Given this list of marker genes DNAJA1, NTF3, IGFBP3, OR51E1, AGT (angiotensinogen), ATXN7, MYO5A, USP26, PAFAH1B2, SBSN, EHD3, FAM117B, SFMBT2, ZC3H12D, UBR1, CA12, FIBIN, CAPN7, TUBB1, RC3H1, ADAR, ARHGEF9, FBXO33, CD247, LRRTM2, NFKBIZ, KCNA5, CCN4, PPP1R42, TEX29, SFR1, KBTBD11, GLS, TSPAN5, HTRA3, IGIP, CST5, SOX3, HES7, CD69, BCAN, LIN37, STAT1, CRIP1, CACNB1, AKT3, FBXL5, MCL1, OR51B6 (olfactory receptor family 51 subfamily B member 6), RGS8, POM121L12, CHD6, OSCAR, DOCK3, COL8A1, CAST, RESF1, SLC1A4, GCOM1, TREML2 (NCBI Gene Id 79865), IAPP, SC5D (sterol-C5-desaturase), PIK3R6, RAI14, LATS2, MALT1, TNFSF9, MTURN, PLS1, ALKBH5, TMPRSS13, RBPJ, DTX3L, SOS1, CEP85, ATXN1, SIAE, ART3, TMCC3, VCPIP1, TSPAN13, PAN3, PPP1R1B, SHROOM2, AHNAK, PTPRU, NUP153 (NCBI Gene Id 9972), MAP9, VWA5A, THY1, CORO2B, C5orf24, CCDC122, FZD2, LNX2, UBASH3B, PRKCB, NUFIP2, PCDHB1, LY75, RBFOX1, KAT7, ECHDC3, NAP1L5, OR51B2, ZNF260, VIM, RRAGD, CYP4A22, FOXN4, LCAT, HMGA2 (NCBI Gene Id 8091), AR, LORICRIN, CNOT6, EPHA2, CYP11B2, GLIPR1, KLF14, SKIL, VAV3, PRKCQ, JMJD6, CYB5R2, TMEM52B, RCN2, DDX17, GRK1, MIS18A, DLG3, PLA2G3, PARP12, C11orf52, UBE2Z, GBP7, ASB4, ZNF790, ASAP1, KRR1, UPK3A, TRPS1, GLRB, SETD5 (NCBI Gene Id 55209), FAAP24, NLGN3, EGR1, PSMB8, FARP2, BCL2, DMRTC1B, PDCD1LG2 (NCBI Gene Id 80380), ZFYVE9, PIGC, PLA2G6, RAP1GAP2, NIPA2, STYXL1, BCORL1 (NCBI Gene Id 93949), MOB3A (MOB kinase activator 3A), CCDC117, IGSF9B, ELOVL5, KISS1R, SLC12A8, CYP27A1, PDE10A, SHISA6 (NCBI Gene Id 388336), KYAT3 (NCBI Gene Id 56267), NEO1, KHDC1L, CHIC1, ERRFI1, CACNB2, PRAP1, IGKC, ITPR2, ARHGAP30, STK10, LAMC1, FAM20C, SOCS4, NDN, TRIM8, INPP5F, TSPYL1, TRPV4, SLAMF6, MED13, MS4A6A, ARR3, UBXN7, VPS13C, GABRE, PRELID3A, TRIQK, RBM7, COL9A1, LRIF1 (NCBI Gene Id 55791), XDH, here is a description of the gene set: Genes down-regulated in bone marrow-derived macrophages with PPARG knockout: control versus IL4. Human Gene Set: GSE25123_CTRL_VS_IL4_STIM_PPARG_KO_MACROPHAGE_DN species: Homo sapiens Conditional macrophage-specific PPARg knockout mice were generated on C57Bl/6 background by breeding PPARg fl/- (one allele is floxed, the other is null) and lysozyme Cre transgenic mice. PPARg and IL-4 signaling was analyzed on bone marrow-derived macrophages. Bone marrow of 3 mice per group was isolated and differentiated to macrophages with M-CSF (20 ng/ml). 20 ng/ml IL-4 was used to induce alternative macrophage activation and 1 uM Rosiglitazone (RSG) was used to activate PPARg. From each mouse 4 samples were generated: 1. M-CSF, 2. M-CSF+RSG, 3. IL-4 and 4. IL-4+RSG. All compounds were added throughout the whole differentiation process, and fresh media was added every other day. Control cells were treated with vehicle (DMSO:ethanol). After 10 days, RNA was isolated and gene expression profiles were analyzed using Mouse Genome 430 2.0 microarrays from Affymetrix. from publication Szanto A, Balint BL, Nagy ZS, Barta E, Dezso B, Pap A, Szeles L, Poliska S, Oros M, Evans RM, Barak Y, Schwabe J, Nagy L (PMID 21093321)